Given this list of marker genes FBXL19, H2AX, SIPA1L3, GTF2H3, NAA40, ZC3H4, CXCL3, GADD45A, SNAPC2, CRKL, DCLK3, FBRSL1, FUS, TNFSF9, MTHFD1L, ERAL1, STARD9, MCM9, MKNK1, TAFAZZIN, THUMPD2, CCDC51, GLRX, AASDH (aminoadipate-semialdehyde dehydrogenase), PARP14, METTL18 (methyltransferase 18, RPL3 N3(tau)-histidine), PWP1, ORC5, PIGM, TCTN3, SAMD9L, FGD4, SUSD6, NCOA6, HPS4, LYST, CENPJ, PTGES, USP18, ESS2, METAP1, TMX4, DNAJA2, RABEP2, MRPL50, ZCCHC18, ZWINT, FSCN1, CHM, PTGDR (NCBI Gene Id 5729), ART3, MINDY1, IFIT1B, GLCE, USP34, TMEM87B, SMUG1, TMEM165 (NCBI Gene Id 55858, transmembrane protein 165), GRIA3, TRIM45, ELAPOR2, CPNE1, ZNF569 (NCBI Gene Id 148266), STXBP3, ATP11C, HEXIM2, URI1, VDR (NCBI Gene Id 7421), GORASP1, SREBF1, KLHL18 (NCBI Gene Id 80077), CKAP4, TOR3A, SLFN13, FGF7, PRPF8, AVL9, CUL1, SHMT1, NFE2L2, ARHGAP1, RANBP6, NR3C2, HEXIM1, NFKB1, DYNC2I1 (NCBI Gene Id 55112), THSD7A, RAP1B, KDM4B (NCBI Gene Id 23030), QRICH1, SYT4, SLCO2A1, IKBKE, ARRDC1, TNFAIP8, BTRC, TEX44, GEN1, TRAPPC10, TRIM60, KLHL2, ZC3H10, GRWD1, SLC52A2, LGALS1, SLC15A3, PTX3, STK36, NOL4, DNAJC28, FOXM1, ZNF638, PIAS1, WDR89, CCDC102A, BATF2, IQGAP3, IL1RAP (interleukin 1 receptor accessory protein), WDR24, TAB1, EXOC4, SHLD1, C8orf48, PARP8, SRP54, TSPOAP1, RFX1, ODF1, PEX16, SLC16A9, UBA6 (NCBI Gene Id 55236), ARV1, DLD, MIB1, MLH1, HPS3, NRDE2, LRRC42 (leucine rich repeat containing 42), ATG16L2, RMND5B, KDM4A, SFT2D3, FADD, ZNF207, ARPP21, IFT70B, METTL3 (methyltransferase 3, N6-adenosine-methyltransferase complex catalytic subunit), APOBEC1, ZC3H6, HNRNPUL2, CREBBP, ING2, NUDT12, FUT10, ZNF483, ZMYND8, WDR11, APBB3, COL6A5, SLC1A4, RPP40, RNF34, ZMYND15, IFIH1, CYBB, CCAR1, LRIF1, LACC1, MTNAP1, IWS1, ITM2B, WDR20, ZNF473, TLR2, RHBDF2, POT1, TIAM1, OR52A1, USP32, PRAP1, CEP85, HCFC1, LRRC28, HSDL1, MLST8, ATP10B, SHPRH, TAP2, ADAM19, TCEANC2, ATP8B4 (ATPase phospholipid transporting 8B4 (putative)), LMO2, KLHL10, PTPN2, ANKRD12, SLC36A1, SCYL3, ASH1L, HYAL2, ABCC1, here is a description of the gene set: Human Gene Set: GSE21546_WT_VS_SAP1A_KO_ANTI_CD3_STIM_DP_THYMOCYTES_DN Genes down-regulated in double positive thymocytes stimulated by anti-CD3: wildtype versus ELK4 knockout. species: Homo sapiens Removal of the transcription factor SAP1a member of the Ternary Complex Factor (TCF) group of transcription factors which in conjunction with Serum Response Factor (SRF) has been shown to have a profound effect on positive selection in the thymus. When another TCF Elk1 is knocked out in mice there is no effect on positive selection unless it is on a Sap1a KO background where the phenotype is very severe. We have stimulated isolated double positive T cells (DPs) with anti-CD3 to mimic positive selection and compared basal and stimulated transcription across the four genotypes to discover the downstream targets of Sap1a involved in positive selection. from publication Costello P, Nicolas R, Willoughby J, Wasylyk B, Nordheim A, Treisman R (PMID 20554967)